Given this list of marker genes SF3A3, TNC, WFDC2, CXCL9, MAGI1, PALLD (NCBI Gene Id 51653), PPME1, SLC25A23, COL1A1, ACY1, SLC2A1, ARMC7, LMLN, KAT14, PRKCA, CEP128, EHD1, ZBTB34, HOXC13, ABHD14A-ACY1, H2AZ1, ATP2B2, FBXO27, AKAP6, SH3TC2, ATN1, ANKS1A, HDLBP, PRR30, NRP2, MLLT6, TOB1, FBXL16, IPPK, TMEM59, TRPS1, PUDP, SIX4, ODF2, BLOC1S3, FCGR3B, BBX, MSI2, SOWAHA, BCAM, S100A9, here is a description of the gene set: Genes predicted to be targets of miRBase v22 microRNA hsa-miR-92a-1-5p in miRDB v6.0 with MirTarget v4 prediction scores > 80 (high confidence targets). studied in species Homo sapiens Human Gene Set: MIR92A_1_5P from publication Chen Y, Wang X (PMID 31504780)